The following is a description of a gene set: species: Homo sapiens Myocardial infarction Human Gene Set: HP_MYOCARDIAL_INFARCTION Necrosis of the myocardium caused by an obstruction of the blood supply to the heart and often associated with chest pain, shortness of breath, palpitations, and anxiety as well as characteristic EKG findings and elevation of serum markers including creatine kinase-MB fraction and troponin., and this is the list of marker genes: IL23R, TP53, CEP19, IL10, DYRK1B, CALR, SCN3B, NKX2-5, IRF4, SCN1B, IL12A (NCBI Gene Id 3592), GATA5, JAK2, HGD, GTF2I, MEF2A, SCN4B, RAF1, ZMPSTE24, TTN, LRP6, ABCG8, EIF4H, RFC2, CFTR, TBL2, CYP27A1, DNAJC30, CCR1, ADAMTS13, ABCC9, VHL, FKBP6, NR3C1, SCNN1B, LPL, C4A, CLIP2, PTPN11, CTNNB1, WRN, MEFV, USP48, UBAC2, IL12A-AS1, NUP155, GATA6 (NCBI Gene Id 2627), IFNGR1, KLRC4, GTF2IRD1, SLC2A10, SCN2B, MYL4, TET2, SH2B3, KCNJ3, THOC2, KCNA5, GLA, GJA5, KCNJ2, PIGA, ERAP1, NPPA, GTF2IRD2, NKX2-6, APOB, PCSK9, BUD23, CELA2A, USP8, FAS, ENPP1, CCND1, CDH23, HLA-B, ABCC6, SCNN1A, TLR4, EPOR, PITX2, KCNE2, NCF1, KCNJ5, ELN, MYH7, LDLRAP1, KCNE1, BAZ1B, STAT4, CBS, MPL, LIMK1, SCNN1G, IL12B, LMNA, TMEM270, ATRX, VPS37D, BCHE, MLX, MYH9, ABCG5, SCN5A, LDLR, GATA4, STX1A, METTL27, KCNQ1 (potassium voltage-gated channel subfamily Q member 1), BRAF, IKZF1, ABCA1